Given this list of marker genes CCT8, CCT3, CCT6A, DKC1, CCT4, TCP1, CCT7, CCT5, CCT2, here is a description of the gene set: studied in species Homo sapiens Human Gene Set: GOBP_POSITIVE_REGULATION_OF_TELOMERASE_RNA_LOCALIZATION_TO_CAJAL_BODY Any process that activates or increases the frequency, rate or extent of telomerase RNA localization to Cajal body.